The following is a description of a gene set: studied in species Homo sapiens The chemical reactions and pathways resulting in the formation of GDP-mannose, a substance composed of mannose in glycosidic linkage with guanosine diphosphate. Human Gene Set: GOBP_GDP_MANNOSE_BIOSYNTHETIC_PROCESS, and this is the list of marker genes: HK1, GMPPA, PMM1, GMPPB, MPI, PMM2